The following is a description of a gene set: species: Homo sapiens Short foot A measured foot length that is more than 2 SD below the mean for a newborn of 27 - 41 weeks gestation, or foot that is less than the 3rd centile for individuals from birth to 16 years of age (objective). Alternatively, a foot that appears disproportionately short (subjective). Human Gene Set: HP_SHORT_FOOT, and this is the list of marker genes: HDAC6, HUWE1 (HECT, UBA and WWE domain containing E3 ubiquitin protein ligase 1), SMAD4, SIN3A, WDR19, LTBP3 (latent transforming growth factor beta binding protein 3), TRIP11 (thyroid hormone receptor interactor 11), GALNT2, CCBE1, SNORD116-1, WDR81, IHH, KDM4B, KCNAB2, TONSL, SIM1, NGLY1, DYNC2LI1, RNF2, NSUN2, MAPK8IP3, CCDC47, CHD6 (chromodomain helicase DNA binding protein 6), SKI (NCBI Gene Id 6497), SLC35C1, SON, UBE2A, FGFR1, MSL3, CUL4B (cullin 4B), HERC2, RTL1, PTH1R, IGF1R, BRD4, MECP2, RERE, GPC3, DYRK1A, DYNC1H1, POC1A, COL11A1, SMC3, NTNG1, UBE4B, PDGFRB, CDKL5, SLC26A2, H4C3, CENPE, NIPBL, SATB2, HTT, TAF6 (NCBI Gene Id 6878), HNRNPR, RAD21, MBD5, ASCC3, BMP2, PRDM16, DYNC2I1, PWAR1, USP9X, MAP3K7, PIGL, CRELD1, RMRP, LMBR1, KIAA0753, PRKCZ, FMR1, SNORD115-1, LUZP1, USP7, DYNC2I2, KIF5C, COL2A1, AHDC1, MMP23B, NPAP1, DLK1, SMC1A, GJA1, SPART, SATB1, PIGN, LAS1L, FGFR2, MKRN3, TBL1XR1, COL3A1, CCDC28B, IFT80, KCNJ5, HDAC4, CASZ1, TBCE, ZFX, RECQL4 (NCBI Gene Id 9401), BGN, BPNT2 (3'(2'), 5'-bisphosphate nucleotidase 2), SNRPN, TRPS1, SHOX, FGFR3, ADAMTSL2, MAGEL2, DYNC2H1, HSPG2, FGD1, GABRD, IFT140, FBXL4, TELO2, NDN, TRRAP, KCNJ2, WDR26, FAM50A, OCA2, ARL6, CERT1, ZMYM2, MASP1, NOG (NCBI Gene Id 9241), IFT172, PWRN1, CEP120, GPC4, COG1, ERI1, TUBB3, CTSK, TTC21B, RNU4ATAC, LIG4, CHSY1, FBN1, CAMK2G, SPEN, GDF5, GABBR2, INPPL1, WNT7A, BMPR1B, FBXO11, PDPN, PPM1D, HDAC8, B3GLCT, WDR35, MEG3, KDM5C, BBS1